Given this list of marker genes GBE1, THEM4, STAMBPL1, TMEM176B, STMN1, HSPA1A, RPL31, RALGPS2, RARG, SLC30A4, KLHL22, RNLS, NRIP1, TRIB2 (tribbles pseudokinase 2), RPS26, ST8SIA6, WWP1, SLC25A27, ATP5F1E, PKIB, CENPT (NCBI Gene Id 80152), RAB4A, ECM1, NDUFC1, LRP5, PDLIM1, CD2AP, CRY1, H2BC3, SESTD1, GPNMB, EML5, ZNRF1, SHCBP1, RNF38, F2RL1, SFT2D2, NPAS2, RPL37, RPS12, ARMCX2, MFHAS1, RORC, NSMCE2, PI4K2A, MYBL1, IL1R1, ZHX3, RPL12, CFAP20, RAB3IP, FBXO17, CERK, RPL38, ITGA7, RPL24, GPR146, CCT5, DST, TREML2, BMAL1, IL17RE, BIK, WDR46, RNY3, CLSPN, RPS19, RETREG1, NIPAL1, UBE3D, POLR2G, IL1RL2, IL23R, HELLS, TRPM6, MRPS5, RIPK3, PGK1, CRLF3, TRAT1, KCNH5, H2AX, TCF7, RPL10, CD93, VAX2, DAPL1, TXNDC16, TMEM176A, NEDD4L, KIF18B, SMAD1, NDUFA6, DTL, LYSMD2, RPS15A, LRP12, RAPGEF4, RFLNB, PLEKHF1, PRMT5 (protein arginine methyltransferase 5), IGF1R, AQP3, GLIS3, RPS20, PKP4, GTF2IRD1, RFPL3S, RAMP1, IL7R, CKB, MIR206, CCR4 (NCBI Gene Id 1233), LEF1, ASB18, F13A1, IGFBP4, SIAH3, NSG2, PIMREG, SYNPO, IFNAR2, CD72, ATP6V1B1 (NCBI Gene Id 525), RPL32, CUTC, ST6GALNAC1 (NCBI Gene Id 55808), CYP2S1, GUCY1B1, CYSLTR1, CDCA5, EMB, KIF23, SH3BP5, ADGRG5, BEX3, RMRP, TRIM25, QPCT, IL17RC, CPM, IL6R, PCBP3, NDRG2, NEBL, DPY19L3, IFNGR2, EEF1B2, FAM124B, BAZ2B, B3GALT4, RPL23, IQGAP3, ACP3, DNAAF11, TANC1, RGS10, CENPP, FAM72A, VIPR1 (NCBI Gene Id 9357), HIPK2, TDRKH, H4C6, CKS1B, TXLNA, LRRC27, ADAM12, here is a description of the gene set: studied in species Homo sapiens IFNs are highly pleiotropic cytokines also endowed with marked anti-angiogenic activity. In this study, the mRNA expression profiles of endothelial cells (EC) exposed in vitro to IFN-alpha, IFN-beta, or IFN-gamma were determined. We found that in HUVEC as well as in other EC types genes were upregulated (>2-fold increase) by IFNs, including genes involved in the host response to RNA viruses, inflammation, and apoptosis. Interestingly, genes showed a >5-fold higher induction by IFN-alpha in EC compared to human fibroblasts; among them, the gene encoding the angiostatic chemokine CXCL11 was selectively induced by IFN-alpha in EC along with other genes associated with angiogenesis regulation, including CXCL10, TRAIL, and guanylate binding protein 1 (GBP-1). These transcriptional changes were confirmed and extended by quantitative PCR analysis and ELISA; whereas IFN-alpha and IFN-beta exerted virtually identical effects on transcriptome modulation, a differential gene regulation by type I and type II IFN emerged, especially as far as quantitative aspects were concerned. In vivo, IFN-alpha-producing tumors over-expressed murine CXCL10-11, GBP-1 and TRAIL, with evidence of CXCL11 production by tumor-associated EC. Overall, these findings improve our understanding of the anti-angiogenic effects of IFNs by showing that these cytokines trigger an anti-angiogenic transcriptional program in EC. Moreover, we suggest that quantitative differences in the magnitude of the transcriptional activation of IFNresponsive genes could form the basis for cell-specific transcriptional signatures. from publication Indraccolo S, Pfeffer U, Minuzzo S, Esposito G, Roni V, Mandruzzato S, Ferrari N, Anfosso L, Dell'Eva R, Noonan DM, Chieco-Bianchi L, Albini A, Amadori A (PMID 17202376) Genes up-regulated in endothelial cells: interferon beta versus IFNG. Human Gene Set: GSE3920_IFNB_VS_IFNG_TREATED_ENDOTHELIAL_CELL_UP